The following is a description of a gene set: Genes up-regulated in comparison of NK cells treated with IL15 versus untreated NK cells. from publication Fehniger TA, Cai SF, Cao X, Bredemeyer AJ, Presti RM, French AR, Ley TJ (PMID 17540585) Murine NK cells were compared at rest and following 24 hours of IL-15 stimulation for their mRNA expression profiles on the Affymetrix MOE430_2 microarray platform. Additional comparators included resting bulk splenocytes. Human Gene Set: GSE7764_IL15_TREATED_VS_CTRL_NK_CELL_24H_UP species: Homo sapiens, and this is the list of marker genes: PATL1, RAD1, ILF2, UAP1, RCC1L, CTR9, COMMD10, GRWD1, NFX1, ALG3, NAT10, TMEM107, NBN, BRCC3, SLC31A1, OSGIN2, HROB, WDR89, PCGF6, HDAC3, CDC25A, MEMO1, HNRNPH2, CDK7, CIT, TIMM21, TMEM39A, XRCC3, SCARB1, CDC45, DUS2 (NCBI Gene Id 54920), TBC1D7, ZWINT (NCBI Gene Id 11130), FMR1, CETN3, POLR3G (RNA polymerase III subunit G), PLAA, ARHGAP11A, CDCA2, ASF1B, NOP9, CRLS1, NCAPG, CMSS1 (cms1 ribosomal small subunit homolog), MBNL3, HELLS, POLE3, CRTAP, AURKA, MVD, MRPS18B, CLSPN, RBMX2 (RNA binding motif protein X-linked 2), RPP40, L3HYPDH, KIF20B (kinesin family member 20B), TMEM97, CDC25C, WEE1, SPRED1, LAP3, MYBL2, ARL6, TM9SF4, EIF1AD, POLR3E, HSPA14, FAM234B, TIMM10, CCNA2, AGK (acylglycerol kinase), SLC25A1, DEPDC1B, THUMPD2, APOO, BRCA1, TIMM9, CARNMT1 (NCBI Gene Id 138199), MTFP1, RGS16, PRPS1, BABAM2, WDR74, PIM2, SAE1, MOAP1, TARDBP, NUBPL, ATAD5, METTL14, FAM174C, WDR43, BLTP3A, PARP2, MID1IP1, E2F3, GOT1, TRIAP1, IPP, TMEM101, PLRG1, DPAGT1, BZW2, METAP2, ENKD1, ARMT1, ELAVL1, UTP4, CKAP2L, CALU, SOCS1, PCLAF, KIFC1, NEK2, HAUS5, TOP2A, RCC2, RAD54L, WDR4, DNA2, ABCF2, RUSF1, EZH2, MTBP, ANKLE1, CENPJ, TYMS, ERRFI1, PTGER3, MTHFD2, SLC9A2, MPHOSPH10, CENPF, EME1, CHADL, PUS3, MAGOHB, UMPS, CDC6, CMTR1, IARS1, TP53RK, TSPAN4, ATAD2, NQO1 (NAD(P)H quinone dehydrogenase 1), MYCN, C5orf15, SEMA6D, GMPR2, DDX20, DGCR6, MASTL, NUSAP1, ATIC, CINP, PKM, NANP, SNX7, MIS12, SLC7A5, SYNCRIP, HAUS1, GEMIN4, KPNA1, UBE2C, HELQ, EXOSC2, CDKN2C, CDC123, GPSM2, PLK4, BIRC5, STK39, FAM111A, URB1, ALYREF, ADGRG3, COPS5, THYN1, TMEM201, HAUS6, MBD4, GSTCD, MRM3, ARPC4, E2F8, HSD17B7, ZWILCH, SLC29A1, MCM3, HAUS7, PPP5C, DKC1, NOP2, USP5, LSM5, UBFD1, ECE2, PRKAR2A, PPAT